The following is a description of a gene set: Mouse Gene Set: ELL_TARGET_GENES Genes containing one or more binding sites for (Ell) in their promoter regions (TSS -1000,+100 bp) as identified by GTRD version 20.06 ChIP-seq harmonization. from publication Yevshin I, Sharipov R, Kolmykov S, Kondrakhin Y, Kolpakov F (PMID 30445619) species: Mus musculus, and this is the list of marker genes: Cdk5rap2, Spcs2, Lmtk3, Pcm1, Erp44, H4c6, Uqcrh, Caml, Ndufb5, Eloc, Tango6, Alyref2, Ddx3x, Sec61a1 (NCBI Gene Id 53976), Snord49a, Ccdc191, Zcchc8, Ifrd1, Kif20a, Swt1, Snord3a, Qars1, Ppcdc, Mau2, Ncln, Gfus, Slc35e2, Usp40, Smarcal1, H2ac5-ps, Wnk1, Ddx23, Rbm6, H2ac13, Plekha1, Mir6236, Szrd1, Rsbn1, Cenpl, Brd8, Zw10, Pemt, Htra2, Prcc, Rnu12, H1f5, Inpp5b, Bcl2l12, Arid4b, Ccp110, Slmap, H2bc15, Tarbp2, Tbx6, Gm11335, Daam1, M6pr, Rpp30, H2bc8, Mrpl50, Invs, Snx27, Crcp, Kpna3, Eny2, Wdr12, Daxx, H4c12, BC051226, Sesn1, Fen1, Znfx1, Slc3a2, Lrrc41, Aplf, Ccdc163, Dync2i2, Ift70a1, Snapc3, Efcab12, Letm1, Smim30, Rnaseh2c, Zup1, D030040B21Rik, Hcfc1, Syt3, Tor2a, Slx4ip, Rnu7, Map1lc3b, Trir, Mir707, Sirt4, Zim1, Nutf2, Gmpr2, Aak1, Tbl1xr1, Zcwpw2, Stradb, Rubcn, Ubqln4, Gspt1, Ccpg1, Sipa1l3, H2bc13, Trak2, Ndufs2, Luc7l, Usp31, Tbc1d17, Wasf1 (WASP family, member 1), Zbtb7a, Fam168a, Usp48, Napb, Zfp133-ps, Camkmt, Cep128, Sec11c, 1600020E01Rik (RIKEN cDNA 1600020E01 gene), Prr14, Zfp933, Ado, Ggps1, Pafah2, Rexo2, Mir1945, Dync1i2, Tssc4, Asl, Nr3c1, Klf2 (Kruppel-like transcription factor 2 (lung)), Hsph1, Spink10, Fto, H2bc4, Snx16, Tmem160, Clpb, Alkbh8, Thrap3, Tacc3, Calcoco1, H2ac7, Cep290, Catsperg1, Esrp2, H4c2, Xrra1, Catspere2, Lig1, Tomm40l, Atp5mf, Rab29 (NCBI Gene Id 226422), Slc35b4, Mcmbp, Cdk19, Foxn4, Gpr108, H2bc3, Smim33, Vps50, Cwc22, Rpgrip1l, Mpi, Vps35l, Klhl26, H2ax, Sh3bp5l, Mmachc, Mir291a, Carf, H4c8, Timm13, Naa38, Neil1, mt-Tq, Lta4h, Stk25, A430005L14Rik, Traf7, Tmem231, Vcpip1, Dnajc17, Scaf1, Ormdl3, Timm22, Zfas1, Dedd, Farsa, Sult6b1, Dffa, Dcps, Csrnp2, 2010110E17Rik, Cnih4, H4c9, Wdpcp, Pa2g4 (proliferation-associated 2G4), Cdc26, Lemd1, H3c10, Gm20753, Scrib, Zfyve1, Clba1, Tmem11 (NCBI Gene Id 216821), Crebl2, Ptdss2, Txnip, Zfp553, Cyb5d1, Lamtor2, AW209491, Trmt1l, Zfp583, Zranb3, Gtpbp2, Phf8, Sirt2, Psmb5, Tmem115, Nfkbib, Rrm1 (NCBI Gene Id 20133), Acad8, Ap2s1, Thyn1, Gm22513, Cenpj, Chchd4, Timm21, Snord118, Dgat1, Grk4, Ncdn (neurochondrin), Tnfaip1, Dnm1l, Phb1, 1700042O10Rik, 4933404O12Rik, Hepacam2, Polk, AU040320, AI480526, Mitf, Cdk5, Khdc4, Malat1, Zscan22, Ptgdr, Fam185a, Zfp354c, Eef1a1, Fbxo46, Nedd8, 1700003G18Rik, Slc12a6, Fdps, Serbp1, H4c14, Slc27a4, Tmem129, Phf12, Tex14, Mindy1, Banp, 1700030K09Rik, Cep57l1, Ranbp10, 2210016L21Rik, Bub1b, Tufm, H2bc7, Odad3, H1f1, Eprs1, Gm23143, Gtf3c6, Cep350, Akt1s1, 9430015G10Rik, H3c13, Zfp37, Cnot4, Trappc2b, Tfeb, Arv1, Usp35, H2bc12, Iftap, Fem1a, Dars2, Usp5, Prpf4, Ndrg3, Exoc7, Ccdc174, Mir290a, H4c4, Eapp, Hspa13, Ap2m1, Upf3b, Vrk1, Desi2, Odr4, Srprb, Snord13, Lcorl, Setmar, Rnu11, Ncoa3, Gm9694, Fbf1, 1110004F10Rik (RIKEN cDNA 1110004F10 gene), Zfp94, Poldip3, Rcc1l, Tial1, Chmp4b, Rps27, Cdca3, H4c18, Syngr1, 1810019D21Rik, Mettl3, Gnai2, Fbxw11, Rbm47, Ppp1r12b, Capn15, Smpd3, Ints9, Irf3, Brd3, Wbp2, Exosc2, Hsp90b1, N4bp1, Cops7b (NCBI Gene Id 27992), Kif13b, Maf1, Itpr1, Cep97, Ifrd2, Creld2, Mrpl34, Gtf2h4, Gsk3a, Aup1, Dcun1d4, Bscl2, Lemd2, Ptpa, Hmga1, Galm, Gm25878, Tpgs1, Rab26os, Atp5po, Eml6, Rab3c, Sdccag8, Rab13, Gm21985, H2ac6, H2bc18, Zfp189, Rif1, Amd1, Chst10, Cep170, Fiz1, Kat7, H1f3, Fis1, Polr2a, Tmtc3, Fbxo38, Nudt13, Serpini1, mt-Tw, Slc4a2, Phf13, Ttc13, Tsnaxip1, Gm15441, En2, Men1, Abcf2, Pprc1, Plekhm1 (pleckstrin homology domain containing, family M (with RUN domain) member 1), Rangap1, Snx1, Ccdc77, Nop16, Uqcr10, Snx5, St3gal2, Nop14, Cdca4, Snord60, Fam222a, Mrps25, Med25, Snord49b, Mir1938, Zfp235, H4c1, Gm6410, Gm25894, Atp5f1d, Otud4, Cilk1, H2bc22, Usf1, Crat, Edem2, Gm25855, Azi2, Micos13, Cct3, Prepl, Eldr, Ccdc107, Zfp46, Pde6d, Pkp2, Gm7008, Hacd2, Lmnb2, Zfyve19, Crtc2, Fbxo9, Fyco1, 1700008O03Rik, 1700034P13Rik (NCBI Gene Id 73331), Dnajc18 (NCBI Gene Id 76594), Tor1a, H1f2, Ndc1, 2410006H16Rik, Mkks, Btrc (beta-transducin repeat containing protein), Car11, Unk, Zfp354a, Mir1955, Ctu1, Gm22973, Cuedc2, Mfsd13a, Ric8b (RIC8 guanine nucleotide exchange factor B), Rdm1, H2ac8, Zfp672 (NCBI Gene Id 68181), Hmbox1, Ralbp1, Oxsr1, Sympk, H2ac22, Pdcd10, Galnt2, Ing3, H3c6, Calr3, Prkcsh, Tmem101, Zfp354b (zinc finger protein 354B), Ccdc124, Josd2, Tmem43, Pcbp1, Krr1, Sharpin, Napepld, Knstrn, Fbxo48, Rmrp, Vipas39, R3hdm1, Tmem258, H4c16, Dut, Ctdp1, H3c2, Slc25a34, Zfp524, N4bp2l2, Ttc33, Kctd21, Alg12, Birc5, Ciao2a, Supt5, Wdr87-ps, Zfp607b, H3c1, 1700042D02Rik, Rnf44, H2ac15, Ahsa1, Taf6, H4c3, Tti2, Bad, Gtf2i, Rab7, Foxa3, E230015B07Rik (NCBI Gene Id 320001), Abraxas2, Prpsap1, Zmat5, Higd2a, Ccdc167, H3f3b, Wrnip1, Bub3, 1110019D14Rik, Rpia, H1f4, Fgf4, Cradd, Grcc10, Smim13, Ccdc146, Gm25939, Zfp1, Phlpp1 (NCBI Gene Id 98432), Gm11520, Tmem63b, Pierce2, Cxxc1, Zfp637, Phf23, Qtrt2, Kbtbd7, H2ac12 (H2A clustered histone 12), Tpr, Cert1, Fastkd1, Mgme1, Cdc40, Ift20, 1700022N22Rik, Rabac1, Txndc15, Zswim9